Given this list of marker genes Gk, Gk5, Gk2, Tkfc, Tpi1, Gpd2, Sord, here is a description of the gene set: Mouse Gene Set: GOBP_ALDITOL_CATABOLIC_PROCESS studied in species Mus musculus The chemical reactions and pathways resulting in the breakdown of alditols, any polyhydric alcohol derived from the acyclic form of a monosaccharide by reduction of its aldehyde or keto group to an alcoholic group.